The following is a description of a gene set: The process that modulates the level of any of the various angiotensinogen proteolytic products in the blood. This occurs by the proteolytic cleavage of angiotensinogen, and its proteolytic products, to create a variety of active peptide hormones, such as angiotensin I and angiotensin II, as well as through the removal of these peptides from the circulation. studied in species Mus musculus Mouse Gene Set: GOBP_REGULATION_OF_ANGIOTENSIN_LEVELS_IN_BLOOD, and this is the list of marker genes: Atp6ap2, Mme, Ndst2, Anpep, Prep, Enpep, Ace, Prcp, Cpa3, Ace2, Mcpt4, Kcnn4, Ren1